Given this list of marker genes MUC2, PARK7, ATP7A, ATOX1, SNCG, SNCB, COX17, PRNP, SNCA, here is a description of the gene set: studied in species Homo sapiens Binding to a cuprous ion, copper(1+). Human Gene Set: GOMF_CUPROUS_ION_BINDING